The following is a description of a gene set: Genes trans-regulated by the hematopoietic stem cell (HSC) proliferation QTL (quantitative trait locus) Scp2. Mouse Gene Set: BYSTRYKH_HEMATOPOIESIS_STEM_CELL_SCP2_QTL_TRANS from publication Bystrykh L, Weersing E, Dontje B, Sutton S, Pletcher MT, Wiltshire T, Su AI, Vellenga E, Wang J, Manly KF, Lu L, Chesler EJ, Alberts R, Jansen RC, Williams RW, Cooke MP, de Haan G (PMID 15711547) We combined large-scale mRNA expression analysis and gene mapping to identify genes and loci that control hematopoietic stem cell (HSC) function. We measured mRNA expression levels in purified HSCs isolated from a panel of densely genotyped recombinant inbred mouse strains. We mapped quantitative trait loci (QTLs) associated with variation in expression of thousands of transcripts. By comparing the physical transcript position with the location of the controlling QTL, we identified polymorphic cis-acting stem cell genes. We also identified multiple trans-acting control loci that modify expression of large numbers of genes. These groups of coregulated transcripts identify pathways that specify variation in stem cells. We illustrate this concept with the identification of candidate genes involved with HSC turnover. We compared expression QTLs in HSCs and brain from the same mice and identified both shared and tissue-specific QTLs. Our data are accessible through WebQTL, a web-based interface that allows custom genetic linkage analysis and identification of coregulated transcripts. studied in species Mus musculus, and this is the list of marker genes: Sftpc, Atp7b, Pbx1, Pold4, Sema5b, Slc50a1, Cetn1, Hsp90ab1, Col4a2 (NCBI Gene Id 12827), Sparc, Zc2hc1c, Nkx2-6, Ctsg, Fmo1, Akr1c13 (NCBI Gene Id 27384), Txnip, Lif, Dnase1l2, Dhx40, Myl4, Psmd3, Myog, Atxn2, Srsf10, Pcsk4, Tep1, Fpr2